Given this list of marker genes CACNA1F, CACNA1C, CACNA1E, CACNA1H, CACNB4, CACNA1S, CACNA1B, CACNB1, CACNB2, CACNA1I, CACNA1D, CACNB3, CACNA1A, CACNA1G, here is a description of the gene set: Enables the transmembrane transfer of a calcium ion by a high voltage-gated channel. A high voltage-gated channel is a channel whose open state is dependent on high voltage across the membrane in which it is embedded. Human Gene Set: GOMF_HIGH_VOLTAGE_GATED_CALCIUM_CHANNEL_ACTIVITY studied in species Homo sapiens